Given this list of marker genes Psmc4, Psmc3, Psmd1, Psma7, Psmb1, Uba52rt, Ubc (NCBI Gene Id 77003), Vcp, Trim21, Ep300, Psmd7, Ubxn7, Sqstm1, Psmc1, Skp1, Psmd13, Prdx1, Ubb, Bach1, Psmb4, Skp2, Keap1 (NCBI Gene Id 54157), Nploc4, Srxn1, Cul1, Sesn1, Psma3, Sesn2, Psmc6, Fbxl17, Psmd8, Ufd1, Psmd11, Gsk3b, Uba52, Map1lc3b, Psmd12, Prkci, Psma4, Psma5, Psma2, Akt2, Akt3, Psmb5, Nfe2l2, Psma1, Psmd14, Mafk, Akt1, Psmd2, Psmd3, Psma6, Prkaa2, Psmd6, Psmc5, Adrm1, Psmb7, Rps27a, Psmc2, Psmb6, Cul3, Psmb3 (proteasome (prosome, macropain) subunit, beta type 3), Mul1, Rbx1, Psmb2, here is a description of the gene set: Mouse Gene Set: REACTOME_KEAP1_NFE2L2_PATHWAY studied in species Mus musculus KEAP1-NFE2L2 pathway